Given this list of marker genes Ccl19-ps1, Ccr7, Gata5, Txn1, Ccl19-ps5, Mapk8 (NCBI Gene Id 26419), Ccl19-ps4, Itgav, Ccl19-ps6, Dpep1, Egln1, Crk (NCBI Gene Id 12928), Kcnc2, Hnrnpd, Traf2 (NCBI Gene Id 98924), Ptpn1, Thbs1, Aifm1, Ccl19-ps3, Scn11a, Gucy1b1, Cflar, Aqp1, Bcar1, Ccl19, Mtr, Ccna2, Atp5f1a, Foxo1, here is a description of the gene set: studied in species Mus musculus Any process that results in a change in state or activity of a cell or an organism (in terms of movement, secretion, enzyme production, gene expression, etc.) as a result of a nitric oxide stimulus. Mouse Gene Set: GOBP_RESPONSE_TO_NITRIC_OXIDE